The following is a description of a gene set: Human Gene Set: GOCC_TORC2_COMPLEX A protein complex that contains at least TOR (target of rapamycin) and Rictor (rapamycin-insensitive companion of TOR), or orthologs of, in complex with other signaling components. Mediates the phosphorylation and activation of PKB (also called AKT). In Saccharomyces, the complex contains Avo1p, Avo2p, Tsc11p, Lst8p, Bit61p, Slm1p, Slm2p, and Tor2p. species: Homo sapiens, and this is the list of marker genes: SESN2, MAPKAP1, PRR5, MLST8, TTI1, MTOR, RICTOR, PRR5L, SESN3